Given this list of marker genes Trim2, Luzp1, Raph1, Lce6a, Rpgr, Htatsf1, Rab39b, Tcaim, Zfp493, Pwwp3b, Klhl11, Mbnl2, Lcorl, Car8, Pabir2, Fst, Ubl4a, Elovl5, Chchd2, R3hdm1, Dnajc3, Hnrnpd, Rab11fip1, Lin7a, Zfp74, Sp3, Gsap, Ube2g1, Cramp1, Nr4a2, Fbxl5, Enpp4, Pdzrn4, Camk2d, Ccar1, Tsc22d2, Plpp1 (phospholipid phosphatase 1), Gca, Azin1, Urb2, Xk, Gpatch2, Vnn1 (NCBI Gene Id 22361), Wars2, Ogn, Plekhg1, Cdkl3, Styx, Cd38, Trub2, Mdga2, Rbbp6, Prrg4, Trp53bp1 (transformation related protein 53 binding protein 1), Col12a1, Mier1, Nrg3 (neuregulin 3), Vmp1, Lin7c, H2bc6, Pxdn, Asxl3, Kcna4, Zdhhc3, Rps6ka3, Trappc13, Rnf139, Tsc1, Gtf2a1, H3f3a, Upk3bl, here is a description of the gene set: studied in species Mus musculus from publication Chen Y, Wang X (PMID 31504780) Mouse Gene Set: MIR_203B_3P Genes predicted to be targets of miRBase v22 microRNA mmu_miR_203b_3p in miRDB v6.0 with MirTarget v4 prediction scores > 80 (high confidence targets).